Given this list of marker genes PDE6B, ATOH7, RBM4B, NR2F6 (NCBI Gene Id 2063), ID2, CRY2, OPN5, BHLHE40, PPP1CC, SIK1 (salt inducible kinase 1), USP2, PPP1CB, CRY1, FBXL3, MTA1, PER1, CRTC1, FBXL21P, TP53, PER2, PPP1CA, PML, RBM4, PER3, here is a description of the gene set: The synchronization of a circadian rhythm to photoperiod, the intermittent cycle of light (day) and dark (night). studied in species Homo sapiens Human Gene Set: GOBP_ENTRAINMENT_OF_CIRCADIAN_CLOCK_BY_PHOTOPERIOD